The following is a description of a gene set: Mouse Gene Set: GOBP_NEGATIVE_REGULATION_OF_ENDOTHELIAL_CELL_DIFFERENTIATION Any process that stops, prevents, or reduces the frequency, rate or extent of endothelial cell differentiation. species: Mus musculus, and this is the list of marker genes: Vhl, Jag1, Notch4, Zeb1, Dsg2, S1pr3, Id1 (inhibitor of DNA binding 1, HLH protein), Foxj2, Acvrl1, Vegfa, Xdh, Tgfbr1